Given this list of marker genes MYCN, NOG, HMGA2, TREM2, MIR181B1, MIR181C, HES5, GPR37L1, ID4, NR1D1, DAB1, NR2E1, NTRK3, F2, NF1, LDLR, here is a description of the gene set: Any process that stops, prevents, or reduces the frequency, rate or extent of astrocyte differentiation. species: Homo sapiens Human Gene Set: GOBP_NEGATIVE_REGULATION_OF_ASTROCYTE_DIFFERENTIATION